The following is a description of a gene set: studied in species Mus musculus Mouse Gene Set: GOBP_MITOCHONDRIAL_TRANSPORT Transport of substances into, out of or within a mitochondrion., and this is the list of marker genes: Slc25a21, Cpt2, Ucp2, Samm50, Romo1, Timm50 (NCBI Gene Id 66525), Eya2, Gsk3b, Mtch2, Tomm70a, Tomm40, Hk2, Slc25a2, Slc25a16, Timm17a, Gsk3a, Slc25a3 (NCBI Gene Id 68101), Adcy10, Ucp1 (NCBI Gene Id 22227), Timm44, Stat3, Agk, Slc25a29, Mcub, Vdac2, Bcl2l1, Cpt1b, Slc25a26, Kif5b, Sfxn4, Grpel1, Mpc1, Slc39a8, Nol3, Gimap5, Dnajc15, Akt1, Tmem14a, Letm2, Gfer, Sfxn2, Bhlha15, Trp53, Htt, Bcl2l2, Mcur1, Hip1r (NCBI Gene Id 29816), Sfxn5, Slc25a32, Ppm1k, Fxn, Pam16, Acaa2, Slc25a46, Trmt10b, Timm13, Stpg1, Slc25a41, Micu2, Rhot2, Abcb7, AU015836, Camk2a, Hif1a, Slc25a36, Timm22 (translocase of inner mitochondrial membrane 22), Sfxn1, Tomm20l, Dynlt1a, Slc25a31, Bcl2l11, Bak1, Ccdc51, Dnajc19, Mrpl18, Vps35, Spg7 (NCBI Gene Id 57358), Mtch1, Aifm1, Ucp3, Zfp13, Dynlt1c, Afg3l2, Smdt1, Grpel2, Fzd9, Naif1, Timm29, Tmem102, Sfxn3, Slc25a33, Prkn, Slc35f6, Maip1, Hsp90aa1, Hspa9, Letm1, Tomm7, Pdcd5-ps, Pink1, Slc8a3, Slc25a40, Opa1, Dnlz, Nptx1, Bnip3, Tst, Mrs2, Chchd10, Abcb10, Slc25a51, Ndufa13, Abcb8, Vdac1, Tomm40l, Atf2, Col6a1, Ier3 (immediate early response 3), Pdcd5, Tomm22, Slc25a28, Cnp, Dynlt1f, Mcu, Chchd4, Tomm20, Slc25a1, Hspa4, Ghitm (growth hormone inducible transmembrane protein), Mtx2, Gclc, Bnip3l, Atp5if1 (ATP synthase inhibitory factor subunit 1), Timm9, Selenon, Mul1, Siva1, Them4, Slc25a37, Slc41a3, Rhot1, Psen1, Timm17b, Micu1, Micu3, Crym, Alkbh7, Bax, Pnpt1, Timm21, Pmaip1, Slc25a4, Bad, Slc25a5, Flvcr1, Timm23, Slc9a1, Mpc2, Bid, Psen2, Slc25a23, Bloc1s2, Timm10, Slc25a20, Slc25a24, Bcl2 (B cell leukemia/lymphoma 2), Ppif, Slc25a10 (solute carrier family 25 (mitochondrial carrier, dicarboxylate transporter), member 10), Mpv17l, Tmem14c, Slc25a38, Itpr1, Hspd1, Bok, Slc25a39, Slc25a15, Dynlt1b, Gimap3, Slc30a2, Slc8b1